Given this list of marker genes Adam24, Dmtf1l, Tmpo, Bfar, Fzd5 (NCBI Gene Id 98335), Slc44a5, Zfp704, Nme7, Kdm6a, Slc7a11, Fchsd2, Sgms1, Fgfr1op2, Dpf2, Dzip3, Ntng1, Pnoc (NCBI Gene Id 18155), Klf6 (NCBI Gene Id 97911), Gdi2, Pik3ca, Uevld, Dcun1d3, Creb5, Camsap2, Anapc1, Tmem67, Arhgap42, Ube2k, Sec14l3, Taok1, Commd8, Crisp4, F13b, Mcfd2, Naaladl2, Ubqln1, Gm11715, Stk39, Azi2, Arhgap32, Oxnad1, Rag1, Kcnmb2 (potassium large conductance calcium-activated channel, subfamily M, beta member 2), Strbp, Itch, Syt1, Aqp4 (NCBI Gene Id 11829), Kcnb2, Clns1a, Dgke, Tiam2, Aftph, Ptprk, Edem3, Arfgef1, Zfhx3, Ttll1, Qki, Saysd1, Rock2 (Rho-associated coiled-coil containing protein kinase 2), Mkrn2os (makorin, ring finger protein 2, opposite strand), Wnk3, Chgb, Nanog, Spopl, Enah, Map7, Gm20815, Prkx, Sp3, Rtn4, Abraxas1, Ap3m1, Cgas, Muc15, Ttll7, Mgat5b, Mrpl3, Asf1a, Rere, Smc5, Gria2, Dcun1d2, Ccdc117, Crim1, Fam76b, Fut9, Acer3, Prex2, Washc4, Adipor2, Galk2, Tent4b, Ano3, Grip1, Tbc1d8b, Ubxn7, Bcl9, P2ry1, Trim2, Milr1, Nrp2, Calhm5, Zfp334, Me1 (NCBI Gene Id 52233), Dph7, Hnrnpdl, Krit1, Golm2, Clec2e, Cfap97, Fhl1, Chst11, Plekhb2, Snap23, Zim1, Lnpk, Zfp872, Ccdc127, Nek1, Zdhhc2, Dab2ip, Elapor2, Actr2, Fgl2, Mia3, Ccdc39, Tmco3, Hectd2, Pnrc2, Cdh7, Ccdc14, Zdbf2 (zinc finger, DBF-type containing 2), Spta1, Ccdc85b, Hecw1, Ubxn2b, Wdr35, Spesp1, Ube2j2, Cxadr, Pgm2, Krcc1, Parp8, Sod2, Nfe2l3, Leprotl1, Cacna2d1, Oprm1, Sycp1, Polr3f, Gucy1a2, Fam228b, Chfr, Arl6, Tnfrsf11b, Six6, Eif4ebp1, Srsf6, Ing3, Eea1, Hook3, Daam1, Fam199x, Ebf3, Cdc73, Pramel7, Fam118a, Shisa6, Rfx7, Igf1, Pld2, Bmp2, Emx2, Tmem164, Naip1, Trio, Ybey, Sema4d, Rnft1, Rora, Hnrnpr, Sumf2, Atrx, Klhl31, Oacyl, Gpkow (G patch domain and KOW motifs), Iqgap1, Nedd1, Cmpk2, Npas3, Rab10, Zfp882, Kmt5b, Ptp4a3, Ikzf2, Pak3, Sec14l1, Cmip, Mtf2, Cibar1, Med1, Grin1os, Lias, Sptbn1 (NCBI Gene Id 268394), Cyld, Larp4b, Atp6v1d, Mctp1, Fam78b, Snhg11, Gda, Rap1gds1, Rasal2, Ubl3, Zfp24, Macroh2a2, Kcnab1, Thyn1, Rgs17, Serpini1, Aldh1a2, Nova1, Sec24a, Sike1, Kbtbd2, Fn1, Sptssa, Mprip, Cggbp1, Dnajc30, Pramel12, Gata6, H2-T24, Fgd4, Stx12 (NCBI Gene Id 100321), Rnase4, Sycp2, Klhdc9, 9530068E07Rik, Rnf111, Myo1e, Dazl, Smarca2, Pou4f1, Homer1, Hnrnpll, Phkg1, Smim13, Cnp, T2, Chrng, Bmi1, Apba3, Zfp11, Ube2w, Sppl2a, Bicd1, Clock, Trappc8, Gja6, Osgin2, Olfm3, Maml1, Slc30a4, Cxcl13, Phldb2, Lrrc39, Rnf44, Meioc, Trim36, Tia1, Dclre1c, Strn3, Maml2, Ggps1, Mrpl1, Slc26a11, Tlk2, here is a description of the gene set: from publication Chen Y, Wang X (PMID 31504780) species: Mus musculus Genes predicted to be targets of miRBase v22 microRNA mmu_miR_1264_3p in miRDB v6.0 with MirTarget v4 prediction scores > 80 (high confidence targets). Mouse Gene Set: MIR_1264_3P